The following is a description of a gene set: mouse primary BMDCs were stimulated with tlr ligands and gene expression changes were profiled on Affymetrix arrays from publication Amit I, Garber M, Chevrier N, Leite AP, Donner Y, Eisenhaure T, Guttman M, Grenier JK, Li W, Zuk O, Schubert LA, Birditt B, Shay T, Goren A, Zhang X, Smith Z, Deering R, McDonald RC, Cabili M, Bernstein BE, Rinn JL, Meissner A, Root DE, Hacohen N, Regev A (PMID 19729616) species: Homo sapiens Genes up-regulated in comparison of dendritic cells (DC) stimulated with LPS (TLR4 agonist) at 0.5 h versus DC cells stimulated with CpG DNA (TLR9 agonist) at 0.5 h. Human Gene Set: GSE17721_LPS_VS_CPG_0.5H_BMDC_UP, and this is the list of marker genes: ZNF598, SLC35A1, SLC25A39, BACE1, FASTKD2, LETM1, TIMM44, BCL11A (BCL11 transcription factor A), GGCX, RFXAP, TOP1MT, TBC1D14, PPIC, FBXL15, MINDY3, IKBKB, PTPRF, DAB2IP, WDTC1, PENK, RBM28, SEPTIN6, FKBP10, TRNT1, ZNF518B, NDUFB4, PCDH20, JOSD2, TGM2, ZBTB21, RTN1, NCDN, BSCL2, AP5S1, PRPF40B, NGDN, ZFHX3, PRSS16, COPS7B, DEPTOR, PQBP1, CARD19, RHBDL3, C6orf136, AKTIP, TFIP11, POLR2B, RASGRF1, IARS1, PRKAB1, UBXN2A, TAF10, TBX18 (NCBI Gene Id 9096), MARCHF5, RAD17, COL10A1, MRPL4, RIN1, ACADS, MAGIX, HLA-E, TANK, TMEM131, ALDH1A2, TESK2, LLGL1, METAP1D (methionyl aminopeptidase type 1D, mitochondrial), RNF25, EEF1G, ST6GALNAC4, SMC6, SPHK2, HNRNPD (heterogeneous nuclear ribonucleoprotein D), GTF2H4, FAM149B1, MTCH2, LSM4, PROZ, PTPN5, DDX18, ZNF704, LSS, PEX6, CHCHD10, MARK4 (microtubule affinity regulating kinase 4), METTL3, TESMIN, SNRPB, MYL12B, GIT1, ABCD1, DDX59, SLC7A13, SLC38A2, SERPINB6 (serpin family B member 6), ZNF281, RPLP0, OSR2, RDH5, TWF1, CLASP1, KPNA2, PSD, DNAJC1, ADCY9, CARTPT, DGKA, ASB4, RCAN3, FSHR, ETFRF1, ADCY4, NCOR1, UQCRC2, INCENP, NELFB, GSC, SOS2, FAAP20, RMND5B, CD99L2, TPRA1, SLC27A2, DNAJC14, RNF183, KLHDC3, TNIP1, MUSK, RIMKLB, CLCNKA, ERF, SLC7A10, ZFHX4, SACM1L, CD6, CS, RBMXL1, ARHGDIG, PAPSS1, HNRNPC, SKP1, WDR62, SLX9, AIFM1 (NCBI Gene Id 9131), ADRM1, GET4, SLC26A6, RNF26, GPATCH4, ATXN2, RRAGD, FBXL20, THSD1, TKT, HHEX, ALAD, IMPDH2, ZNF768, SATB1, GPR19, RPL23, PNO1, RECK, TTLL1, ANKRD13C, MAML1, HHAT, DMAP1, BRDT, LRBA, CEACAM21, RPA1, TTK, ADNP2, ANAPC16, HSPB2, TNFSF11, PCDHB1, ACOT7, CAVIN4, HSD17B4, MTHFD1, IFI30, IKBKG, PARD3, POLDIP3, MTX1, TSC1, TEX15, GPANK1, VEGFC, MRTFA, GNL3, ST8SIA1, CRLF2, SLA, DDX49, BLTP3A